Given this list of marker genes MIR205, MIR187, LYN, SHARPIN, NLRP6, SOCS5, PPP1R13L, FEM1A, ELANE, MIR221, PTGIS, NR1D2, IL10RA, NT5E, DUSP10, PLCG1, PLA2G10, NR1D1, PPARG, IL13, ACP5, IL4, MIR31, LRFN5, MIR142, NR5A2, MAPK14, GNAS, MIR105-1, MACIR, TAFA3, IER3, SELENOS, CST7, RORA, SMPDL3B, C1QTNF3, IL12B, CYLD, WFDC1, TYRO3, GATA3, ISL1, GPER1, PTPRC, SAA1, NLRX1, ALOX5, SYK, PSMA1, IRGM, TRIM45, MIR181B1, MIR15A, NR1H4, TNFRSF1B, RABGEF1, APCS, MIR20A, DSG2 (NCBI Gene Id 1829), CD200R1 (CD200 receptor 1), YES1, NFKB1, SIGLEC10, MIR16-1, IL20RB, LDLR, SIRPA (NCBI Gene Id 96784), LPCAT3, GHRL, APOA1, MIR149, FOXP3, MIR138-1, MIR590, IL10, GHSR, PPARD, MIR920, SBNO1, PTGER4, NLRC3, SMAD3, PLK2, FPR2, REG3A, MIR222, SYT11, ACOD1, IL2RA (interleukin 2 receptor subunit alpha), MIR766, SLC39A8, MIR141, FOXF1, ARNT, ADORA1, MIR19A, TEK, PTPN6, PYDC2, MIR181C, PGLYRP1, IL17A, FXR1, TREM2, MIR15B, MIR488, MIR26A1, IL22RA2, CD200, GPR31, NLRP3, ENPP3, MVK, NR1H2, TRIM65, MIRLET7G, NR1H3, MIR223, MIR302E, TNFRSF1A, FFAR4, NLRP12, OTULIN, MIR146A, IGF1 (NCBI Gene Id 3479), SOCS3, FYN, METRNL, MIR30C2, CCN3, SOD1, MIR92A1, MIR204, KRT1, NPY, PTPN2, MIR3909, RPS19, NDFIP1, MIR19B1, IL22, SRC, FGR, FURIN, CDH5, SLAMF8, GBA1, GPX1, BCR, C1QTNF12, MIR199A1, SPN, MIR6869, ADA, TNFAIP3, GPS2, MMP26, IL22RA1, GIT1, PSMB4, MAPK7, CLEC12A, MDK, UACA, RHBDF2, FAM76B, APOE, IL33, GRN, PPARA, FCGR2B, MIR145, MIR4286, AOAH, TNFAIP6, HGF, TMSB4X (thymosin beta 4 X-linked), CYP19A1, ADORA2A, HLA-DRB1, NPY5R, CXCL17, KLF4, VPS35, MEFV, AHR, ADIPOQ, ELF4, CX3CL1, STAT3, PBK, IL2, RB1, MIR195, HCK, INS, MKRN2, ASH1L, GSTP1, TNFAIP8L2, PROC, PRKCD, MFHAS1, GPR17, MIR181A2, EXTL3, FNDC4, here is a description of the gene set: species: Homo sapiens Any process that stops, prevents, or reduces the frequency, rate or extent of the inflammatory response. Human Gene Set: GOBP_NEGATIVE_REGULATION_OF_INFLAMMATORY_RESPONSE